Given this list of marker genes PTPN11, GID4, GFUS, RAB21, GTPBP3, SPHK2, BSG, GTF2H1, FAM210A, UQCC6, DYNLT2, SNRNP35, U2SURP, CLPTM1L, EPN1, FLCN, GBA1, KPNB1-DT, MIX23, CTNS, RPS27L, DPM2, ATG4B, HUS1, HNRNPM, RTF2, TEAD4, LMNB1, METTL15, SLC35F5, CFL1 (NCBI Gene Id 1072), PCBP1-AS1, DDX23, ZSWIM6, PAFAH2, RMND1, SCAMP3 (NCBI Gene Id 255017), CDKN1A, TUBBP11, COG5, TPP1, MFSD5, TMEM11-DT, AKAP3, CTU1, RPS6KA5, UNG, BCL10-AS1, SHARPIN, KNSTRN, STAM2, ACTR10, ANKLE2, SCN4B, XRCC1, ARHGAP27, ATP6V0D1, NDUFV1 (NCBI Gene Id 4723), SLC48A1, SSR4P1, PASK, HNRNPD, RAB4B, PSKH1, MAP3K12, TTBK2, VTRNA1-1, LACTB2, LINC01556, GADD45B, LINC01387, SMIM8, CREBL2 (NCBI Gene Id 1389), NLN, CNN1, CCDC78, ARRDC3-AS1, NEK6, USP15, MED29, SNORD104, MRPS2, CEP128, GNPTG, PRPF31, DVL2, GOLPH3L, SPG21, NOSIP, NBEAL2, COX5AP1, ZBED6, RRAGC, GDF15, SLC35B1, MRPL19, ATG14 (autophagy related 14), BCAS3, FRG1GP, ANXA8, TSNAXIP1, ACTR1B (actin related protein 1B), DPF1, ZC3H6, RAB5B, COL17A1, FRG1-DT, XRN2, CDC42BPG, MELTF, NUBPL-DT, EXTL1, TPT1-AS1, EXOSC8, RBKS, VCPIP1, PPRC1, ATP6V1H, GPALPP1, RPL23AP7, NME6, CAPN1, CSHL1, GAN, TMEM39A, LNX2, TXNRD2, RNVU1-6, PLD3, MRM3, PELP1, DAB2IP, FBXO15, METTL14, CLN3, FAM187A, MRPL34, CEP250, HJV, MAZ, FDX2, ZNF268, ATP6V0B, STRADB, POM121, LINC02918, LINC02210-CRHR1, CCDC77, BIN2 (bridging integrator 2), PLAG1, RNU11, UBR4, PBX2P1, OSER1, TNFAIP8L1, RNVU1-2A, BICDL1, MAN2A1, MAGOH-DT, C1orf35, SLC35B2, NDOR1, IGF2R, NFYC, SCARB1, MRRF, NUP133-DT, ENSG00000237101, ENSG00000272008, CLCN7, MECR, KIAA1143, MED15, COASY, LINC02532, ATG10, TRAF4, BCAR3, AMD1, NUFIP1, G6PC3, CLCN6, KSR1, OR2B2, KDM6A, ACOT8, GALNT16-AS1, MIR4521, HSPA6, H1-0, CTDP1, PPP1R10, PKN2, IGSF9B, KXD1, MFN2, DPP9, BAX, MEGF9, SHPK, ADAMTSL5, GSTCD, TBC1D20, ZFYVE1, CNNM3, EIF3D, HDAC4-AS1, EXD3, SEPTIN9, UBOX5, MTHFSD, IKZF2, ATP6AP1L, ELOB, PCNX2, C8orf33, ZNF775, ENSG00000282904, BNIP3L, QTRT2, ST13, AOPEP (NCBI Gene Id 84909), RN7SL1, LRRC8D, MFSD4A, GOT1-DT, CHAMP1, SRSF11, NUP155, ZNF148, SRPK1, CHN2, NOL4L-DT, GRK3-AS1, UQCRH, NCBP2, REPIN1, WDTC1, DPP3-DT, TAF11, AP4M1, ENSG00000275765, CALR, PIGL, LAX1, APIP, TCERG1L-AS1, USP35, MED9, PRMT1, SNRPD1, VPS33A, FADS1, DOCK7-DT, PINX1-DT (NCBI Gene Id 101929229), IKZF3, ERMARD, TOB1-AS1, ONECUT2, MIR1285-1, CALM2, SYNPO, SLC35E1, CREBRF, KAT5 (lysine acetyltransferase 5), NCOA6, SUB1, CRK, CSRP1-AS1, OGT, ZFYVE16 (NCBI Gene Id 9765), CEP15, PHF21B, HECTD3, ANKRD17-DT, TMEM259, ZNF341-AS1, UNC79, FAM120AOS, MED17, ATXN1L, RWDD1, KDM6B, VAMP1, NET1, PRKCSH, THAP4, VPS37A, DND1P1, NSMCE2, PRR4, PRRG2, CDK8, B4GALNT3, DRAM1, FAM222A, ZNRD2, ATP13A2, VCPKMT (NCBI Gene Id 79609), SLC50A1, RAB4B-EGLN2, TMEM147-AS1, STN1, TRIM41, EFCAB8, ST6GALNAC2, GARS1-DT, NUCB1, SLC25A51, PAN2, URAHP, DHRS1, EDDM13, PSME3IP1, CNOT7, FAM228B (NCBI Gene Id 375190), PI4KB, PGBD4, DYNC1LI2-DT, TBC1D22A-DT, IDH3B-DT, OTUB1, RFC1, RAB24, SAFB, LINC02971, CCDC43 (coiled-coil domain containing 43), NDUFA9, LONP2, RPL38, EFTUD2, CHCHD2P6, LRIG3-DT, TRIM32, COTL1, MADCAM1, OSER1-DT, GPAM, FYCO1, CHMP6, CENPF, ADARB1, CTIF, TRIAP1, NSMCE4A, IPO13, HSDL1 (NCBI Gene Id 83693), SNORD46, EGLN2, SGO1, PHLDB3, SCAI, PSMD1, PANK4, LINC01623, DPPA3P6, NDUFV1-DT, SCN8A, BAP1, ARMC8, SSU72-AS1, PTCD1, RPL23, SKIC2, FAM114A2, SDHAP1, CSRNP1 (NCBI Gene Id 64651), SNORA21, KLHL42, KISS1R, KIF16B, RNASE11, DENND6A-DT, ZSCAN25, ZFTRAF1, RN7SKP175, UBN1, FAF1, PHYHD1, NUP85, TBCK, EIF2B5-DT, ZNF839, POLR3E, TSN, PC, LONP1, ALMS1P1, TRAK2, RPA1, MARK4, ZNF721, RPS27A, CFDP1, ZNF846, SLC25A12, SRRD, GUSBP1, DHX40, CTDSP1 (NCBI Gene Id 58190), UQCR11, BICRA, ATP5MF-PTCD1, CCDC191, DYNC1LI2, EMC1, PLTP, MDN1, RFT1, ADAMTS17, SMAD3, CPNE7, ZNF628-DT, RNU6-8, EARS2, TMEM116, STRADA, NTMT1, FBXL9P, CYB5R4, SETD1A, XPO4, AP1G1, SPNS1, UBXN1, CMAS, AUP1 (AUP1 lipid droplet regulating VLDL assembly factor), WDR43, H3C12, SLC49A4, RPL6, AIMP1, KNL1, TRAPPC2L, KIAA1671, UROD, RMDN3, SOCS4, MIPEP, NCBP2AS2 (NCBP2 antisense 2 (head to head)), C2orf92, SNX17, MCU, PTPDC1, CPVL, NISCH, AKIRIN2, PHF5AP7, CNPPD1, STOML2 (stomatin like 2, NCBI Gene Id 30968), TNS4, ARRDC3, B4GAT1, NTHL1, RPL26, GPR137, ARMC9 (NCBI Gene Id 80210), ZNF576, SECISBP2, MDH1, DUS2, IPP, ZNF554, GSTZ1, STK25, FEM1A, RERE, FARS2, DDX51 (NCBI Gene Id 317781), ANKRA2, CSRP1, FASTKD5, MTND1P29, EMC3-AS1, SRRM5, TRAP1, TMEM94, ZDHHC12-DT, COMMD3, SLC38A10, COQ5, SAFB2, NR2F1-AS1, POLR1D, NOP9 (NOP9 nucleolar protein), UBA52, PLIN4, SEPHS1, LRRC37A3, RGS5, MDFI, CDKN2C, TRAK1, LPP-AS2, TRMT44, AP2S1, BTBD7, PIAS4, DCP1B, ARHGAP26, ABCA7, SLC29A3, MRPL36, KLF3P1 (NCBI Gene Id 651815), SLC25A20, PPEF1, SEPTIN7P14, TBL1XR1, EXD2, ZDHHC24, KDM5B, CTSA, RN7SL3, BCL9L, PSMB3, GAMT, TIMM22, GALNS, RCAN1, BPTF, ETV6, LINC02136, ORC3, CDKL3, GGNBP2, CYCS, FDXR, ENSG00000269210, DBI, LTA4H, SMCO4, ERP29, MCOLN1, CHD6, ZNF687 (zinc finger protein 687), SLC35F6, PEX3, ATF6-DT, ATF6, TKT, RAPGEF1, GABARAP (NCBI Gene Id 201246), RN7SL832P, RHBDL1, COL6A3, ZNF594-DT, SUPV3L1, CRISPLD2, PYCR2, ARHGAP22, TRMT2A, CDK9, PRRC2C, DPP3, GH2 (NCBI Gene Id 2689), TIGD6, FGFR2, SF3B6, ENSG00000272195, TAGLN, BICRA-AS2, AGBL5, C19orf44 (NCBI Gene Id 84167), TAF9, FMNL2, ZDHHC4, SUCLG1, SLC38A7, H2BC5, FAM118B, ST6GALNAC6, USP31, HEXD, ST3GAL2, NUP153, EYA2-AS1, ENSG00000268129, TUBA1C (NCBI Gene Id 84790), TULP3, WASHC2A, SSNA1, PRMT5, SUMF1, METTL26, KRT18, OSBPL8, MALAT1, MCRIP2 (MAPK regulated corepressor interacting protein 2), ZC3H3, ZNF140, NCLN, C12orf43 (chromosome 12 open reading frame 43), SMARCE1, POGZ, AFF4, RPS8, UBE4A, LINC02453 (NCBI Gene Id 651743), GGPS1, CCT3, CLASP1, C19orf47, CDC73, SYNJ2, CCNG2, B3GNT5, RILPL2, CDK5RAP2, MGA, ZNF383, MIR1289-1, MED13, GDF5, ATE1, RPL31, PLB1 (phospholipase B1), TSSC4, CACYBP, ATP6V1C1, ARID4B, RAD23A, SURF6, DUS4L, NEMF, HAGH, PDCD6IP, WDTC1-DT, EDF1, HTRA2, TRAPPC6B, ESF1, RPUSD4, TMEM115, ATP6V1G1, SEPTIN9-DT, RERG, FAM21FP, NCOA7, PLXND1, EIF4G2, ABCB9, NRBP1, LINC02210, DHDDS, INTS3, TRPV4, CCT4, H3C10, BTG2, TIMM21, ENSG00000201701 (novel transcript), MAGOH, WDR20, LCDR, VPS11-DT (VPS11 divergent transcript), BAZ2A, TRIM7-AS2, DLGAP2, FBXW2, BEX3, TMEM203, COMMD1, DZANK1, ENSG00000246308, GPRASP3, AMN, MIR5087, MYLK3, GOSR2-DT, MAST3, GNA15-DT, ZNF23, EPS8L1 (NCBI Gene Id 54869), CCDC107, RPL18, ZAR1L, NAT10, GTPBP6, PPP4R3A, LATS2, CLSTN3, MIR4638, GFI1B, SYT8, WASHC2C, RNVU1-14, NOL10, PSMD12, COPS8, DCTN1, UTP15 (UTP15 small subunit processome component), PMEL, NAF1, GPRIN1, RARS2, CYLD, SNHG30, NAGPA, STAM, DEPP1, RNU4-2, TJP3, PLIN5, CDK4, TBX2-AS1 (TBX2 antisense RNA 1), MYCBPAP, HLA-DPB1, FRMD6 (NCBI Gene Id 122786), LRIG3, GOLGA5, RNF166, B3GALT9, HPS4, MDM2 (NCBI Gene Id 84825), ARHGEF33, MAF1, LGALS1, ENSG00000275740, SRC, MR1, LRP3, TOM1, TMEM232, LINC02028, MFAP3, PPP2R5E, TMEM9, RRP15, ZBED5-AS1, RPS23, KCTD21, CSTB, YBX1, UQCC4, RNASEK, TMEM11, MIR1249, SDAD1P1, SPACA9, RCE1, UBFD1, PTPRG-AS1, RN7SL2, HMG20A, POLDIP2, ICE1, PRPF39-DT, ZDHHC3, PLAC9P1, VPS50, GSTA4, ECD, ANKRD17, RTEL1-TNFRSF6B, METAP1D, ZNF2, AMDHD2, RPS28, VPS4B, WIZ, USP48, CCDC86 (NCBI Gene Id 79080), TAS2R14, REXO1, FAM193A, PRKD2, USF3, CIDECP1, COX7C, ACP5, FAM21EP, ATP6V0D1-DT, RPS6KB2, DOLK, LRRC8D-DT, PPP1R13L, COQ7-DT, CCDC12, SWSAP1, AHCY, RAD17, RPL23AP82 (NCBI Gene Id 284942), PIGG, FRA10AC1, PITPNA, RNF217, SRCAP, CCDC103 (NCBI Gene Id 388389), FAM174C, LINC00963, PANK3 (pantothenate kinase 3), INPP5B, ID2, SSBP3 (single stranded DNA binding protein 3), CWF19L1, BCL10, PRH1, CSNK2B, ZNF133, CCDC194, PNPLA6, EXOSC7, CRACDL, FOXJ3, ATG7, TEDC2, SEMA7A, CALCOCO1, PLIN2 (NCBI Gene Id 123), MIR378D2HG, LINC00475, RANBP1, KLHL22, FRAT2, TMEM59, STX16-NPEPL1, COG4, WIPI1, MPRIP, NDUFB6, ENPP3, BOD1, PDLIM7, LINC00652, SLC27A4, CHD9NB, RNASEK-C17orf49, FBXO31, PHF7, ATF1, NUBPL, MLX, GNA11, PEPD, LDAH, MRPS5, FANCD2, HSPBAP1, EIF2B4, GNPDA1, ORMDL3, TMEM199, CALR3, WFDC3, PDIA5, EPB41L4A-AS1, FERRY3, H2AC17, ING3, ZNF444, PRELID1, RNF185, ATR, MRPL4, ATXN2-AS, EIF2B2 (eukaryotic translation initiation factor 2B subunit beta), SMPD3, IST1, ZNF514, BEAN1-AS1, TOMM40, UBE2Q1, DPH3, WDR11-DT, AFF4-DT, TRMT61B, UNK (NCBI Gene Id 85451), WDR55, GNG7, ILF3-DT, GPANK1, ERCC1, ITFG2-AS1, KIAA0930, STX16, MEMO1, PTMA, TCEA2, ZNF687-AS1, LASP1, PELP1-DT, RBM27, GARS1, SEMA6A, TSC1 (TSC complex subunit 1), STK17B, HNRNPF, RNA5SP200, PIP4P1, WDPCP, WDR81, GZF1, RNMT, PTPRF, NFKBIZ, MIR3928, RRAGC-DT, FAM193B, RGS9, NELFB, DUSP10, DDX31, HM13, MIR7845, SRFBP1, CARD11, ANKRD24, GCLC, KRT19, RBM15B, BCL2L2, MED23, CACTIN, POLG, DOHH, PRPF3, TPM4, SDE2, CCNL1, BAZ1B, PDE4A, MFF, ARID3A, HDLBP, LINC02851, PHF23, ANKHD1-DT, TIA1, ZNF26, PRPF39, ATP6V0E1, GSK3A, SRM, RNASE7, DIMT1, BLOC1S1, AASDH, STAT1, BEX4, MIA3, CCDC125, AP2B1, IQANK1, FOXA3, MIR181A2HG, RETREG2, NELFA, ADAMTS6 (NCBI Gene Id 345667), PHLDA3, KAT6A (lysine acetyltransferase 6A), RCBTB1, MIR4727, HPS5, GET4, DDA1, PIERCE1, SNORA50C, MRPS18B, MED13L, ATPAF2, TBX6, HRCT1, ARHGAP12, AIDA, HNRNPD-DT, CLEC1A, CWC25, HPS1, TSR3, GMFB, ATF4, H2BC17, MED27 (mediator complex subunit 27), RHNO1, POLR1G (NCBI Gene Id 10849), TRPM7, EMC3, LST1, SULF2, TTLL11, PTDSS2, LINC00578, KMT5A, PPP1R37, COPS8-DT, MIR3677HG, LINC01719, PLIN3, POLG-DT, NDUFV2-AS1, SLC2A3, GTPBP10, RNU2-27P, SEC11C, H2AX, HMGB2, TULP4, VPS11, C2orf49-DT (C2orf49 divergent transcript), NDUFAF1, ICAM1, ENSG00000263011, SNORD55, ATP5MF, LINC00452, NDUFAF5, METTL14-DT, GLDC, RNF138, TPT1, BRWD1, NME1, NDC1, TCEANC2, MAP1LC3B (NCBI Gene Id 81631), OXNAD1, BTG2-DT, SRD5A1, MIR5093, CTU2, PSMG2, RPS29P8, FOXM1, MIR548AW, CASTOR3P, GTPBP2, SLC38A6, DFFA, CENPA, PDLIM1, CLK3, PIPOX, DYM, DDX59, VTI1B, TDG (NCBI Gene Id 93091), NUCKS1, H3-3A, SNX29, RAB7A, SNORA13, SNORD60, NELFE, AAMP, ACTN2, ARMT1, NDUFS4, EIF4H, TBC1D22A, EHMT2, GNS, SLC35B4, DCTN6-DT, RNU4ATAC, ACTN1-DT (ACTN1 divergent transcript), TNFAIP1, FLVCR2, CALM1, EML6, ILF2, SMYD4, GTF2IP13, SENP5 (NCBI Gene Id 205564), RBP5, KLRK1, NUMB, TRAF7, RPS29, GALT, RHOF, SLC25A4, TPR, PAF1, HCG14, LMTK3, WDR36, ODR4, MAPKAPK5, RAD51AP1, PROSER2-AS1, LINC02846, DEPDC1, PSMB10, C4orf19, DHX35, SPOCD1, FOS, NME1-NME2, STX18, TELO2, IFRD2, NLRX1 (NLR family member X1), MRPL30, RNVU1-28, STMN1, AP5Z1, RXRA, NSUN2, RBM18, CEP44, IER5, SNHG25, CHMP4B, UBAC1, IPO11, RNVU1-21, PKD2L2-DT, PIM3, STX18-AS1, HPS3 (NCBI Gene Id 85393), C7orf25, RPGRIP1L, ACOX3, ALDH3B1, GTF2IRD1P1, PTPRS, THUMPD1, ANAPC2, DDX11L17, IDH3B, PARD3B, METTL13, RTEL1, STMN3, KANSL1, PWP1, CMBL, PPIAP44, GALNT3, STARD7, PSMC3, CSRNP2, HIP1R, RDH13, YPEL5, HDAC5, HMGXB3, FXN, PIDD1, EMC4, ASTN2, GSPT1, BROX, ZBED5, VPS37D, LINC00200, ZCCHC2, CUL3, ZDHHC12, NICOL1, DPH7, GTF2IP12, SHFL, ASB3, PDHX, ZNF292, DNAAF1, PMAIP1, ZNF594, LRRC40, SOCS2, TERC, RNF44, ZNF507, GLYR1, EIF2B1, EHD2, PRMT3, RN7SK, PHLDB1, DENND6A, ALG5, CDK20, SYNRG, HSP90AA1, DCP2, LOXL1, SNHG19, ATXN3, LILRB3, ADAT2, SLC35A5, PRMT5-DT (NCBI Gene Id 101926933), ACTN3, ACTN1, RNASE4, REV3L (NCBI Gene Id 7807), POP4, RBBP5 (NCBI Gene Id 5929), LMBR1, STT3A, MTHFR, BDP1, ILF3, METTL25, RELB, WDR5-DT, N4BP1, LINC00620, BRPF1, ZNF274 (zinc finger protein 274), TRMT5, XKR9, RPS7, VTRNA1-3 (NCBI Gene Id 56662), KIF15, PPIL4, SIRT1 (sirtuin 1), MAGOHB, KLF7, GATC, CCDC174, ANG, TUBA1B (tubulin alpha 1b), ASXL1, RNA5SP146, H3-3B, EMC7, RABL2A, ANKRD12, B4GAT1-DT, NDUFS7, SPPL3, RHEBL1, CENPW, ANKHD1, GRK6, CFAP418, RNVU1-27, ANP32A, GOSR2, VDAC2, IFT20, RLF, KILH (NCBI Gene Id 101927136), CEP152, POLR2E, RPL7L1, FAHD1, SFSWAP, WASHC5, DCTN6, TSACC, TUBA1B-AS1, HNRNPAB, NPHP1, CDS1 (NCBI Gene Id 1040), HMG20B, C2orf42, C1GALT1C1L, UBR5, MORF4L1, KPNB1, TSFM, NUP188, WDR74, SLC9A6, AGBL5-AS1, SEPTIN2, TMEM208, ZFYVE26, ENSG00000232995, SAMD13, TADA1, GLT8D2, LYRM4, KDM5C, COMMD4 (COMM domain containing 4), WDR47, XPNPEP3, MFSD1 (NCBI Gene Id 64747), ENPP2, EIF1B, MIR3181, GLOD4, KLC1, EPS15, SMARCC2, PPP1R12C, MFF-DT, PDSS2, FOXO3, PINX1, CHD8, ALG1, NDUFA7, CEP76, HDAC4, ABT1, FTO, COX7A2L, MRTO4, RPTOR, NF2, SET, EYA1, MIR4497, ECHDC2, LRRC41, DRG2, BEAN1, COG2, H3-3A-DT, PPP2R3B (NCBI Gene Id 28227), KLHL12, KCNK15-AS1, DYRK4, LMNB1-DT, WDR11, ERLEC1, DNAJC8, SH2D3A, FMC1, C2orf76, DNTTIP1, MAPKAPK5-AS1, MRPL9, INTS12, SHF, KMT2A, ENSG00000227218, VRK3, ZC3H11A, HOXC13, UBQLN1, PPP6R3, STAM-DT, DGLUCY, KDM3B, WDR5, HAGHL, MYO9B, ZNF473, C1D, RAD18, NDUFA3, PLEKHG2, ANKHD1-EIF4EBP3, UBQLN1-AS1, DYNLRB2-AS1 (DYNLRB2 antisense RNA 1), MIR4273 (NCBI Gene Id 100422955), POMT2, HCFC2, YBX3, NSG2, VASP, STH (saitohin), PLXNA2, EMC1-AS1, RAB11FIP5, CDCA3, ZNF585B, ARID1B, YWHAQ, DBP, TMBIM4, TRAPPC3, LAMC3, STPG3-AS1, MAX, FAM162A, DOCK7, SLC36A1, IRGQ, GORAB-AS1, MMP2, TRAF3IP2-AS1, PURB, PTPRE, UBE2D2, TFPT, DYRK1A, ZNF131, LINC01962, SPRYD4 (SPRY domain containing 4), VGF, TAFA2, LINC01503, BSG-AS1, RANBP6, LINC01270 (long intergenic non-protein coding RNA 1270), CFAP410, NDUFA10, AK6, LRP1, ERBIN, TBL3, RPS9, KDM4C, FRG1HP, TBK1, TAF1B, SLC31A2, TSPAN9, THRAP3, KCNK1, PGPEP1, TFCP2L1, FRG1, NMRK2, UBE2B, EIF5A2, LAMP1, NUP214, NUP133, COMMD8, CTDP1-DT, RHBDF1, RCOR1, PDP1, ADPGK, MALSU1, PPP1R7, ADGRB2, EIF4G1, WWP2, SRA1, RANBP2, MCM7, SGO1-AS1 (SGO1 antisense RNA 1), DMGDH, MAD2L1BP, PHACTR2, RBM42, MITD1, MARCHF8, WDHD1, SERF2, CLEC16A, SF3B3, SPTLC1, RANBP10, SSU72, IL23A, FAM149B1 (NCBI Gene Id 317662), CMTR1, PHF12, HMOX1, VPS37C, TRAPPC8, RAD9A, LNPK, MARVELD2, PLAGL2, DDX59-AS1, CLHC1, EIF1B-AS1, PKD2L2, FMC1-LUC7L2, SYTL1, RABL2B, GADD45A, HEXA, SBF2, ANGEL1, G3BP1, CHMP1B, TMEM147, COMMD3-BMI1, KCTD5, CAPN2, PEMT, C2orf49, BCL2L2-PABPN1, NCF4, TNPO2, MIGA2, SLC12A4, RPN1, PNKD, EIF2B5, TIGD1, LINC00470, SEPTIN7P2, ZNRD2-DT, RPS12, MFSD4B-DT, BRCA2, HAUS8, CCDC9, ACTL6A, COQ7, LOXL4, GORAB, ATG4C, REV1, MYH9, ERLIN2, ATXN2, POLR3F, ATAD2, DSE, GATB, DNPH1, CHMP1A, LINC00511, PURPL, NFX1, ITGA7, ZNF767P, LINGO1, FBXO8, TMCC2, DHX35-DT, NEURL2, PACRGL, RIN2, H4C8, EXOSC3, RNPS1, NOC4L, SLC7A6, SYMPK, OAZ3, TBC1D19, SMASR (NCBI Gene Id 102723481), LVRN, RAB11A, CCDC59, COMMD9, TPM1, SMARCAL1, TOMM5, NUF2, GPN2 (NCBI Gene Id 54707), C2, CRPPA, ZNF628, GRAMD2B, POLR2K, ISLR2, NVL, SCFD1, BABAM2, TSC2, SNORD101, ATG3, GTF2H3, FXYD5, HEXA-AS1, CHCHD7, here is a description of the gene set: studied in species Homo sapiens Human Gene Set: ZSCAN5DP_TARGET_GENES Genes containing one or more binding sites for (ZSCAN5DP) in their promoter regions (TSS -1000,+100 bp) as identified by GTRD version 20.06 ChIP-seq harmonization. from publication Yevshin I, Sharipov R, Kolmykov S, Kondrakhin Y, Kolpakov F (PMID 30445619)